Given this list of marker genes Bcl11a, Cc2d1a, Caprin2, Ptn, Rab17, Shank3, Fcgr2b, Dynlt1f (dynein light chain Tctex-type 1F), Prex1, Abi1, Asap1, Zfp365, Cdk5r1, Dvl1, Lrp8, Pak4, Grin1, Cux2, Pias2, Kif1a, Dcdc2a, Lpar1, Igf2bp1, Afdn, Kndc1, Mfn2, Dtnbp1, Prkg1, Dgkg, Atg16l1, Abl1, Dnm3 (NCBI Gene Id 98663), Rere, Csmd3, Iqgap1, Gpx4, Arf4, Skor2, Mef2a, Ankrd27, Psen1, Trpc5, Strn, Sult4a1, Adam10, Nfatc4, Cd3e, Wls, Ntn1, Dlg5, Trak1, Dbn1, Cdk5, Ngfr, Fbxw8 (NCBI Gene Id 75791), Bdnf, Id1, Map2, Nsmf, Crebbp, Hnrnpk, D16Ertd472e, Ntn3, Ppp3ca, Nlgn2, Lst1 (leukocyte specific transcript 1), Ywhah, Rap2a, Dpysl5, Bbs1, Map1s, Cdc42, Cdc20, Actr2, Sipa1l1, Crp, Baiap2, Mapkapk5, Crtc1, Hecw1, Trappc4, Pak2, Slitrk5, Mfn1, Chat, Ctnnd2, Itsn1, Tanc2, Il1rapl1, Kalrn, Zfp296 (zinc finger protein 296), Hecw2 (NCBI Gene Id 329152), Elavl4, Pten, Caprin1, Opa1, Cit, Cpeb3, Plk2, Abi2, Srcin1, Lzts1, Chrna3, Dclk1, Dbnl, Vldlr, Neurog3, Cacna1f, Obsl1, Bbs4, Eif4g2, Cux1, Sema4d, Ptprs, Lrp4, Nr2e1, Map6, Rapgef2, Sdc2, Zfp212, Tbc1d24, Akap5, Prmt3, Abitram, Cyth2, Ulk4, Gsk3a, Camk1, Robo1, Crkl, Foxo6, Tsc2, Cdkl3, Tlx2 (NCBI Gene Id 545897), Mef2c, Rbfox2, Epha5, Arf1, Mink1, Scarf1, Slc11a2, Matn2, Pqbp1, Fas, Arhgap44, Ezh2, Mapk6 (NCBI Gene Id 70413), Sez6, Phactr1, Sgk1, Arf6, Tnik, Arhgap33, Pafah1b1 (NCBI Gene Id 94322), Map1a, Pacsin1, Ctnna2, Fat3 (FAT atypical cadherin 3), Nr3c1, Met, Mpdz, Bmp7, Dlg4, Shank1 (SH3 and multiple ankyrin repeat domains 1), Gpr37, Parp6, Syngap1, Nrp1, Grn, Ptprz1, Clip1, Prickle1, Dhx36, Zdhhc15, Ss18l1, Arc, Nedd4, Abi3, Dynlt1b, Srgap2, Picalm, Adgrb3, Sema3a, Nck2, Disc1, Chrna7, Fbxo31, Marcks, Ube3a, Ppp1r9a, Lzts3, Rapgef4 (Rap guanine nucleotide exchange factor (GEF) 4), Pbrm1, Slc12a5, Ngef, Actl6b, Mcf2, Eef2k, Bhlhb9, Numb, Acsl4, Rab21, Cobl, Mapk8, Camk2b, Sdk1, Mark1, Il2, Gsk3b, Igsf9, Dact1, Septin7, Atp7a, Pak3, Camk1d, Ephb1, Nlgn1, Rock2, Tulp1, Efna1, Dab1, Llph, D130043K22Rik, Wnt5a, Pdlim5, Neurl1a, Dnm1l, Alk, Crk, Ptprf, Rtn4ip1, Lrrk2, Farp1, Ntrk2, Kidins220, Klf7, Uba6, Dynlt1a, Myo5b, Tpbg, Zmynd8, Cask, Btbd3, Camk2a, Fezf2, Mir132, Gorasp1, Mapk8ip2, Celsr2, Mgarp, Spire1, Dip2a, Itpka, Nlgn3, Grin3a, Xlr3b, Cyfip1, Git1, Trak2, Ache, Anapc2 (NCBI Gene Id 99152), Palm, Ephb2, Ppfia2, Fstl4, Stk11, Hdac2, Sh3glb1, Ndp, App, Wasl, Numbl, Pak1, Dab2ip, Khdc3, Slc9a6, Fmr1, Itgb1, Cul7, Cfl1, Iqsec1, Mir212, Abl2, Tet1, Camsap2, Wnt7a, Arid1b, Sarm1 (NCBI Gene Id 97709), Mtor (mechanistic target of rapamycin kinase), Tmem106b, Abi3bp, Carm1 (coactivator-associated arginine methyltransferase 1), Grip1, Cacna1a, Actr3, Reln, Stau2, Ppp1r9b, Ntn5, Rhoa, Slc30a1, Taok2, Chrnb2, Flrt1, Apoe, Fyn, Hprt1, Rac1, Tiam1, Fzd4, Ilk, Cdkl5, Hdac6, Dcx, Slc25a46, Dscam, Cntnap2, Ptprd, Nedd4l, Ghrl, Mecp2, Bmp5, Trpc6, Ephb3, Dock10, Dynlt1c, Prex2, Mfsd2a, Myo6, Map1b, Klhl1, Epha4, here is a description of the gene set: studied in species Mus musculus Mouse Gene Set: GOBP_DENDRITE_DEVELOPMENT The process whose specific outcome is the progression of the dendrite over time, from its formation to the mature structure.